The following is a description of a gene set: Any process that stops, prevents, or reduces the frequency, rate or extent of leukocyte proliferation. Human Gene Set: GOBP_NEGATIVE_REGULATION_OF_LEUKOCYTE_PROLIFERATION studied in species Homo sapiens, and this is the list of marker genes: TNFAIP3, GNRH1, TNFRSF21, MIR181C, ENPP3, PLA2G2F, BTK, CD80, IHH, TWSG1, TGFB1, TNFRSF13B, GPNMB, LILRB1, LILRB2, LRRC32, VSIG4, FOXP3 (NCBI Gene Id 50943), ITCH, SHH, CRTAM, PDCD1LG2, TYROBP, INPP5D, RASSF5, SPN, ZBTB7B, CRP, MAD1L1, CASP3, SFTPD, CD86, HLA-E, SCGB1A1 (NCBI Gene Id 7356), TNFRSF14, CLEC4G, IL33 (NCBI Gene Id 90865), IL10, ATM, IL2RA, LGALS9B, TSPAN32, DLG1, SCRIB, CEBPB, CD37, SDC4 (syndecan 4), CBLB (Cbl proto-oncogene B), IL2 (interleukin 2), VSIR, SLC4A2, BCL6, MNDA, CTLA4, LAPTM5, PRKAR1A, PELI1, PHF7, PAWR, GSTP1, PRNP (prion protein (Kanno blood group)), PTPN11, LYN, RC3H1, LILRB4, LGALS9C, ARG1, ARG2, PLA2G2D, PKN1, CDKN2A, LST1, PTPN6, IDO1, SOX11, BTN2A2, ERBB2, GREM1, NDFIP1, PLA2G5, HLA-DRB1, MARCHF7, RIPOR2, LGALS9, TMEM131L, GLMN, DLG5, XCL1, PLA2G2A, CCL8, BMP4, CR1, GAL, NF1 (neurofibromin 1), CD300A, IL20RB, HAVCR2, HLA-G, MIR185, CD274, VTCN1, BTLA, FCGR2B, IL4I1, FOXJ1